The following is a description of a gene set: species: Mus musculus Any process that increases the frequency, rate or extent of the chemical reactions and pathways resulting in the metabolism of collagen, any of a group of fibrous proteins of very high tensile strength that form the main component of connective tissue in animals. Mouse Gene Set: GOBP_POSITIVE_REGULATION_OF_COLLAGEN_METABOLIC_PROCESS, and this is the list of marker genes: Serpine1 (serine (or cysteine) peptidase inhibitor, clade E, member 1), F2r, Ccl2, Serpinf2, Il18, Gli2, Wnt4, Ep300, Vim, Bmp4, Creb3l1 (cAMP responsive element binding protein 3-like 1), Pdgfb, Mkx, Tgfb3, Ihh, Cbx8, Acvr1b, Eng, Dicer1, Ucn, Uts2, Vsir, F2, Scx, Idua, Itga2, Ccn2, Serpinb7, Pdgfrb, Tgfb1, Larp6, Ltbp1, Rgcc, Ddr2, Suco, Arrb2, Retn, Prdx5, Inhba, Myb